The following is a description of a gene set: Human Gene Set: GOBP_NEGATIVE_REGULATION_OF_ALPHA_BETA_T_CELL_ACTIVATION species: Homo sapiens Any process that stops, prevents, or reduces the frequency, rate or extent of alpha-beta T cell activation., and this is the list of marker genes: NDFIP1, SOCS5, ZBTB7B, LGALS9, TBX21, STAT5A, CLEC4G, ZC3H12A, CD274, SOCS1, FOXP3 (NCBI Gene Id 50943), TARM1, DAPL1, RUNX3, ASCL2, CD69, TNFSF18, JAK3, LOXL3, GLI3, LGALS1, ADORA2A, ITCH, RUNX1, TNFSF4, HFE, LGALS3 (NCBI Gene Id 81625), RC3H1, VSIR (V-set immunoregulatory receptor), HLX, SLC4A2 (NCBI Gene Id 96677), LGALS9B, CBFB, BCL6, ANXA1, XCL1, TNFRSF14, IHH, LILRB1, HMGB1, ARG2, SHH, IL2, SMAD7, TWSG1, CBLB, CD300A, RC3H2, IL4R, LGALS9C